Given this list of marker genes ORC4, SLC37A4, HECTD2 (NCBI Gene Id 196026), NRAS, RAI1, SEMG1, SATB2, RSPO2, ADPRHL1, SCUBE3, CYP26B1, MID1, PTCHD4, HS3ST5, CASQ2, PLAC1, HOXB3, HOXB8, DCAF11, JAZF1, ESRRG, SPINK4, C8orf34, CRYAB, IPCEF1, RNF113A, SESN3, BACE2, SRSF2, NDUFA1, CNTLN, XYLT2, GPR22, RBFOX1, HIPK1, NF1, WNT9A, MGLL, EWSAT1, FOXP2, IKZF2, FUT11, VASN, NRP1, ELOVL3, UBXN1, UBXN10, BMP10, FABP2, ACTR1A, IL22, RHOG, LPAR4, H4C3, MEF2A, TDRD5, PLAG1, TYRO3, LMO3, SH3BGRL2 (SH3 domain binding glutamate rich protein like 2), KLF14, STOML2, ONECUT2, RBM39, CTNNA3, IL4, ARHGDIB, ZRANB1, EHF, NEK6, NCDN, CACNA1D, RRAGA, TOB1, CLEC1B, OLIG3, CSMD3, TRMT44, LMO2, RAB1B, ASIC2, SMAD5 (SMAD family member 5), ADAMTS3, IGF1, TMEM62, MSX2, TSC1, LUC7L, SUFU, GNAO1, MGAT4C, PPARGC1A, XCR1, USP2, HOXA1, SIX1, SORCS1, OGN, NEUROD6, TSHB, IRX5, MBNL2, SOX11, SOX5, MS4A4A, NCAM2, HNF1B, MBNL1, SOX14, MAP2K5, RFX4, LUC7L3, HHEX, DNAJC1, POU4F2, TMEM47, SRPK2, RTN1, UBE2R2 (NCBI Gene Id 54926), AZI2, IL7, HOXB5, DMD, LGI1, TCEAL9, FAM91A1, CDK14, VAMP1, MYCT1, AMMECR1L, ISL1, ENOX1, PKHD1L1, PCYT2, UCKL1, SLC44A1, HOXB7, MEIS2, TMOD4, SLC43A2, CHD2, GRM3, HOXD10, C12orf42 (chromosome 12 open reading frame 42), CPNE1, LIX1, UBE2K, ZFPM2, SLC26A9, LRTM1, PTGFR, LINC00898, CHCHD7, ELAVL4, SALL3, ACTC1, ARHGAP8, HSPB2, KCNJ13, PI15, ROS1, FHL3, KIZ, CDK2AP1, ZFPM1, NTN4, PTGDR2, MTMR10, CDH9, CREB5, HOXA3, RUNX1T1, HCN1, HTR3B, here is a description of the gene set: Human Gene Set: EVI1_05 studied in species Homo sapiens Genes having at least one occurrence of the motif AGATAAGATAN in the regions spanning 4 kb centered on their transcription starting sites. This matches the EVI1 transcription factor binding site V$EVI1_05 (v7.4 TRANSFAC).